The following is a description of a gene set: Human Gene Set: GOBP_HISTONE_MRNA_CATABOLIC_PROCESS species: Homo sapiens The chemical reactions and pathways resulting in the breakdown of histone messenger RNA (mRNA)., and this is the list of marker genes: XRN1, MTPAP, TUT1, TUT7, EXOSC10, ERI1, DCP2, SSB, TENT4B, TUT4, EXOSC4, ATM, TENT2, UPF1, LSM1